The following is a description of a gene set: from publication Iritani BM, Delrow J, Grandori C, Gomez I, Klacking M, Carlos LS, Eisenman RN (PMID 12234922) Activated lymphocytes must increase in size and duplicate their contents (cell growth) before they can divide. The molecular events that control cell growth in proliferating lymphocytes and other metazoan cells are still unclear. Here, we utilized transgenesis to provide evidence suggesting that the basic helix-loop- helix-zipper (bHLHZ) transcriptional repressor Mad1, considered to be an antagonist of Myc function, inhibits lymphocyte expansion, maturation and growth following pre-T-cell receptor (pre-TCR) and TCR stimulation. Furthermore, we utilized cDNA microarray technology to determine that, of the genes repressed by Mad1, the majority (77%) are involved in cell growth, which correlates with a decrease in size of Mad1 transgenic thymocytes. Over 80% of the genes repressed by Mad1 have previously been found to be induced by Myc. These results suggest that a balance between Myc and Mad levels may normally modulate lymphocyte proliferation and development in part by controlling expression of growth-regulating genes. Genes up-regulated by overexpression of MAD1 in primary thymocytes from RAG2 knockout mice. studied in species Mus musculus Mouse Gene Set: IRITANI_MAD1_TARGETS_UP, and this is the list of marker genes: Akr1c13, Cpa3, 0610009E02Rik, Pik3r1, Ciao2b, Mycn, Ago2, Trgc3, Slc43a3, Scin (scinderin), Ltb, Eif2s3y, Tulp4, Mxd1, Hsd11b1, Uggt1